The following is a description of a gene set: species: Mus musculus from publication Chen Y, Wang X (PMID 31504780) Mouse Gene Set: MIR_760_5P Genes predicted to be targets of miRBase v22 microRNA mmu_miR_760_5p in miRDB v6.0 with MirTarget v4 prediction scores > 80 (high confidence targets)., and this is the list of marker genes: Slc38a9, Rbm5 (NCBI Gene Id 83486), Pigc, Notch4, Nhsl2, Dcun1d1, Rundc3b, Stx6, Pggt1b, Braf, Necap1, Scamp2, Vcan, Aptx (NCBI Gene Id 66408), Aph1a, Ccser2, Tet2, Aifm2, Fam219a, Vash1, Niban1, Slc25a19, Elavl4, Frmpd4, Pianp, Ces2e, Pnpla5, Zfp612 (NCBI Gene Id 234725), Abca13, Rora, Usp5, Tpgs2, Foxf1, Ppp2r2c, Nasp, Lhx3, Cplx1, Ifi27l2a, Kcnip1, Pdpk1 (NCBI Gene Id 18607), Ep300, Cldn19, P2rx1, Padi2, 1700025G04Rik (NCBI Gene Id 98629), Tmem71, Uvssa, Tardbp, Rfx3, Bcl2l1, Layn, Sval1, Tmem132b